Given this list of marker genes Klhl17, Cul3, Zbtb21, Atxn1, Atxn1l, here is a description of the gene set: species: Mus musculus Binding to a POZ (poxvirus and zinc finger) domain of a protein, a protein-protein interaction domain found in many transcription factors. Mouse Gene Set: GOMF_POZ_DOMAIN_BINDING